Given this list of marker genes RN7SL41P, LINC01607, TPM3P3, PRR13P7, TMEM70, ZFAND1, LRRC69, SLC10A5, SLC26A7, MIR2052HG, TRPA2P, THAP12P7, RPS26P34, DECR1, NECAB1, CA3-AS1, MRPL9P1, ENSG00000287352, PRXL2AP2, DPPA3P9, GDAP1, LINC03071, LINC02839, CASC9, LY96, RNU7-85P (NCBI Gene Id 124902076), UBE2W, ENSG00000253699, RUNX1T1, HNRNPA1P4, PSMC2P2, UBE2Q2P10, RPSAP47, CHMP4C, ZFHX4-AS1, PEX2, MIOXP1, ENSG00000253726, ENSG00000246792, RALYL, RN7SKP231, LINC02849, CKS1BP7, CRISPLD1, RDH10-AS1, KCNB2, STAU2, HMGB1P41, SLC10A5P1, CPP, ZFHX4, RLIG1P3, FABP5, LINC01030, RN7SL308P, PIP4P2, HNF4G, RPS3AP32, LINC02605, RPL7, FABP9 (NCBI Gene Id 650715), PMP2, RNU6-1300P, GYG1P1, GOLGA2P1, SBSPON, PARAIL, RNU6-1040P, CA1, RNU11-6P, CNGB3, LNMICC, TRPA1, CA13, TERF1, JCHAINP1, RPL13AP18, RPL3P9, PKMP4, REXO1L11P, REXO1L1P, RMDN1 (regulator of microtubule dynamics 1), REXO1L10P, ENSG00000254251, REXO1L9P, RNA5SP273 (NCBI Gene Id 100873526), RNU2-71P, TMEM64, RIPK2, VENTXP6, RPS20P21, PCBP2P2, COX6B1P6, ENSG00000206649, ATP6V0D2, STAU2-AS1, STMN2, IARS2P1, FABP12, RNU6-285P, REXO1L5P, REXO1L4P, OSGIN2, PI15, CA3, ENSG00000249328, MIR5681B, RNA5SP272, ENSG00000303615, CA2, IMPA1, LINC01111, CPNE3, RN7SL107P, ENSG00000254288 (NCBI Gene Id 105375903), KRT8P4, HNRNPA1P36, LINC00534, PKIA, E2F5-DT, RNU6-1197P, MIR3149, SOX5P1, RPSAP74 (NCBI Gene Id 107075113), MIR4661, MITA1, MIR5708, DCAF4L2, WWP1, WWP1-AS1, LINC01419, MRPS28, MIR2052, TPD52, ENSG00000253214, RNA5SP271, ENSG00000254394, PSKH2, UBE2HP1, LINC02986 (NCBI Gene Id 123689089), REXO1L12P, ACTBP6, RNU7-174P, CNBD1, REXO1L8P, SNX16, ENSG00000253778, RDH10, PKIA-AS1, CALB1, PAG1, IL7, FABP4, NIPA2P4, RPL36AP31, JPH1, REXO1L6P, ZNF704, ENSG00000287927, IMPA1P1, RNU2-54P, RNU6-1220P, REXO1L2P, NBN, MMP16, SLC7A13, HIGD1AP6, REXO1L3P, C8orf88, SLC25A51P3, E2F5, LINC02886, RNU6-1213P, LRRCC1, NTAN1P2, ZC2HC1A, HIGD1AP18, MRPS16P1, SLC2A3P4, VTA1P2, HEY1 (NCBI Gene Id 23462), ENSG00000285758, C4orf46P3, RPL32P4, DSTNP3, MIR5681A, HAUS1P3, OTUD6B-AS1, LINC02235, RBIS, ELOC, RN7SL760P, ZBTB10, RNU6-925P, OTUD6B, FTH1P11, C8orf89, here is a description of the gene set: species: Homo sapiens Human Gene Set: chr8q21